The following is a description of a gene set: from publication Gutiérrez NC, Ocio EM, de Las Rivas J, Maiso P, Delgado M, Fermiñán E, Arcos MJ, Sánchez ML, Hernández JM, San Miguel JF (PMID 17252022) Human Gene Set: GUTIERREZ_CHRONIC_LYMPHOCYTIC_LEUKEMIA_DN studied in species Homo sapiens Genes exclusively down-regulated in B lymphocytes from CLL (chronic lymphocytic leukemia) patients but with a similiar expression pattern in the normal cells and in the cells from WM (Waldenstroem's macroblobulinemia) patients. The tumoral clone of Waldenström's macroglobulinemia (WM) shows a wide morphological heterogeneity, which ranges from B lymphocytes (BL) to plasma cells (PC). By means of genome-wide expression profiling we have been able to identify genes exclusively deregulated in BL and PC from WM, but with a similar expression pattern in their corresponding cell counterparts from chronic lymphocytic leukemia (CLL) and multiple myeloma (MM), as well as normal individuals. The differentially expressed genes have important functions in B-cell differentiation and oncogenesis. Thus, two of the genes downregulated in WM-BL were IL4R, which plays a relevant role in CLL B-cell survival, and BACH2, which participates in the development of class-switched PC. Interestingly, one of the upregulated genes in WM-BL was IL6. A set of four genes was able to discriminate clonal BL from WM and CLL: LEF1 (WNT/beta-catenin pathway), MARCKS, ATXN1 and FMOD. We also found deregulation of genes involved in plasma cell differentiation such as PAX5, which was overexpressed in WM-PC, and IRF4 and BLIMP1, which were underexpressed. In addition, three of the target genes activated by PAX5 - CD79, BLNK and SYK - were upregulated in WM-PC. In summary, these results indicate that both PC and BL from WM are genetically different from the MM and CLL cell counterpart., and this is the list of marker genes: VASH1, CCDC88A, FCER2, SFMBT1, ATXN1, TOP6BL, CDK14, DNMBP, ROR1, RXRA, TRAC, ID3, FMOD (fibromodulin), AGPAT5, COL9A2, LEF1, PGGHG, VAMP1, ZFP64, COL9A3, RUBCNL, DBI, CCR7, NOSIP, TTN, SPOCK2, NEK3, PTPN22, PDGFD (NCBI Gene Id 80310), ABCA6, PTPRO, MAP3K5, RAPGEF3, WARS1, CELSR1, ALDH3A2, GCLC, FCMR, MARS1, IGSF3, PEBP1, LPP, FILIP1L, SPATS2L, PBX3, SYT17, HIVEP2, DPEP2, KCNN4, GBP2, PNMA1, INPP5F, FRY, APOBEC3G, LCK, ABR